Given this list of marker genes HNRNPM, NUP188, SMS, MRPS18A, MIS18A, TRIB3, LSM4, COX6A1, ATF6, GADD45GIP1, TOMM40, ASNS, UROD, COX17, RECQL4, MKI67, NFYC, NDUFA8, SLC25A17, C1D, MEFV, PAM16, PWP1, ATP5PF (NCBI Gene Id 63498), RANGRF, TUFM (NCBI Gene Id 7284), NFE2L3, UTP3, FOSB, DHRS7B, DCTPP1, ELP5, USP10, SLC12A2, HSD17B10, HDGF, PSMA4, PSMD13, TMEM165 (transmembrane protein 165), HIGD1A, TPI1, POLD1, CALU, NDUFS3, MRPL39 (NCBI Gene Id 64977), BNIP1, GLMN, NCKIPSD, UFD1, CYP1B1, ORAI2, ATP5F1B (ATP synthase F1 subunit beta), JTB, ALDOA, HNRNPK, LETM1, GMPPA, PMAIP1, LSM7, ERCC6L, CLPP, ALDH1B1, DESI2, VBP1, COA3, RAB5IF, EPB41L2, MED6, TK1, RPP30, DNM1L, GINS4 (NCBI Gene Id 84296), POGLUT2, RMI1, MNAT1, PTBP1, TRIM24, CCDC59, TADA2A, PUS1, MTX2, CPOX, RFC5, C2orf49, SERPINB8, MRPL48, TPRKB, PRPF19, PLAA, CISD1, COX8A, STAP2, GGH, UTP6, TCERG1, UQCRFS1, STEAP1, TFPT, GNL3, TBCE, PMM2, SF3B2, REEP4, DYRK3, KPTN, CDK7, ATG101, H3C7, SNRPD2, DDX46, DNAJA3, HTRA2, PSME2, SCD, POLR1G, DHODH, TIMM8A, G0S2, IFT27, POP7, PSME3, EEF1E1, DNPEP, MMACHC, ACTR3, TPD52, GOT2, NOL7, RAD50, CAVIN3, NUDT6, SEC23B, TTF2, PARK7, HAT1, GOT1, PNP, LSM12, MRPL11, MTX1, RAE1, ZNF706, RTCA, SDHB, ACO2, POP4, GOLT1B, CS, PPP1CC, B3GNT2, TMEM11, SNAP29, PRIM1, NOP14, TRAF1, HNRNPC, MYBBP1A, AGPS, CCT8, TBRG4, SMC2, POLDIP2, MRPL12, BMS1, PDHA1, SKA1, IFT25, ACTB, RPE, GEMIN2, MRPL16, PPIH, MRPL23, KIF14, PIAS2, NDUFS7, OXSM, PSMA3, DNAAF2, TIMM8B, EXOSC9, IDE, PLAGL2, ALAS1, CALM3 (calmodulin 3), UBXN8, UQCRH, SENP3, CYP51A1, PPRC1, TAF1A, PKMYT1, NUP58, GPI, EIF6, NIT2, INTS12, UMPS, CDC23, GFUS, here is a description of the gene set: The transcriptome of naive OT-I T cells was compared to memory CD8 T cells after 1, 2, 3, or 4 infection with ovalbumin expressing Listeria monocytogenes (LM-OVA). from publication Wirth TC, Xue HH, Rai D, Sabel JT, Bair T, Harty JT, Badovinac VP (PMID 20619696) studied in species Homo sapiens Genes up-regulated in memory CD8 T cells: 2' versus 3'. Human Gene Set: GSE21360_SECONDARY_VS_TERTIARY_MEMORY_CD8_TCELL_UP